The following is a description of a gene set: from publication Chen C, Ouyang W, Grigura V, Zhou Q, Carnes K, Lim H, Zhao GQ, Arber S, Kurpios N, Murphy TL, Cheng AM, Hassell JA, Chandrashekar V, Hofmann MC, Hess RA, Murphy KM (PMID 16107850) species: Mus musculus Genes down-regulated in testis from 4 week old ETV5 knockout mice. Mouse Gene Set: CHEN_ETV5_TARGETS_TESTIS Division of spermatogonial stem cells produces daughter cells that either maintain their stem cell identity or undergo differentiation to form mature sperm. The Sertoli cell, the only somatic cell within seminiferous tubules, provides the stem cell niche through physical support and expression of surface proteins and soluble factors. Here we show that the Ets related molecule (ERM) is expressed exclusively within Sertoli cells in the testis and is required for spermatogonial stem cell self-renewal. Mice with targeted disruption of ERM have a loss of maintenance of spermatogonial stem cell self-renewal without a block in normal spermatogenic differentiation and thus have progressive germ-cell depletion and a Sertoli-cell-only syndrome. Microarray analysis of primary Sertoli cells from ERM-deficient mice showed alterations in secreted factors known to regulate the haematopoietic stem cell niche. These results identify a new function for the Ets family transcription factors in spermatogenesis and provide an example of transcriptional control of a vertebrate stem cell niche., and this is the list of marker genes: Mki67, Rad51, Dck, Ccnb1ip1, Crabp1, Cdk2, Rbl1, Haus6, Dazl, Ak4, Ddx10, Rnf227, Xlr3c, Mad2l1, Sox3, Dmc1, Mcm2, Nfyb, Hells, Rbmy, Ccne2, Tgfbr1, Tktl1, Stra8, Cdca7